The following is a description of a gene set: Mouse Gene Set: GOBP_CELLULAR_RESPONSE_TO_INDOLE_3_METHANOL studied in species Mus musculus Any process that results in a change in state or activity of a cell (in terms of movement, secretion, enzyme production, gene expression, etc.) as a result of an indole-3-methanol stimulus., and this is the list of marker genes: Jup, Ctnna1, Ctnnb1, Brca1, Cdh1